The following is a description of a gene set: The process of regulating the proliferation and elimination of monocytes such that the total number of monocytes within a whole or part of an organism is stable over time in the absence of an outside stimulus. Mouse Gene Set: GOBP_MONOCYTE_HOMEOSTASIS studied in species Mus musculus, and this is the list of marker genes: Ccl2, Mpl, Sh2b3, Csf1r, Csf1